Given this list of marker genes Alox8, Prxl2b, Fads1 (fatty acid desaturase 1), Mif, Scd1, Acot8, Fabp5, Ptges3-ps, Elovl6, Daglb, Acaa1b, Tbxas1, Sirt1, Ptgis, Ptgs2, Mapk9, Fads3, Il1b, Pibf1, Elovl4, Pnpla8, Elovl2 (NCBI Gene Id 54326), Abcd2, Ptgds, Ptges, Anxa1, Avpr1a, Hsd17b4, Elovl5, Alox15, Scd4, Cd74, Pla2g3, Fads2, Ptges2, Alox12, Elovl7, Abcd1, Acsl4, Hpgds, Edn1, Ptgs1, Pla2g10, Tmem135, Sphk1, Cthrc1, Scd3, Ehhadh, Scp2, Edn2, Ptges3, Pla2g4f, Decr2, Fads2b, Avp, Sco1, Scd2, Acaa1a, Elovl1, Elovl3, Pla2g4a, Acox1, Pla2g2a, here is a description of the gene set: species: Mus musculus The chemical reactions and pathways resulting in the formation of an unsaturated fatty acid, any fatty acid containing one or more double bonds between carbon atoms. Mouse Gene Set: GOBP_UNSATURATED_FATTY_ACID_BIOSYNTHETIC_PROCESS